Given this list of marker genes KDM5A, CDV3, SIPA1, CYBC1, HLA-C, TAP1, PSMB8, WIPF1, HLA-E, PHF11, HLA-A, MFNG, CD48, VAV1, IFI16, ELF4, CYTIP (cytohesin 1 interacting protein), RNF4, CD53, CORO1A, PSMB10 (proteasome 20S subunit beta 10), PSD4, PSME1, ARF6, GRK6 (NCBI Gene Id 2870), ACTR3, STAT6, RAC2, HCLS1, CSK, WAS, HLA-B, ARHGDIB, LAPTM5, CSNK1G2, TAPBP (NCBI Gene Id 6892), RAP1B, HLA-F, INPP5D, CBFB, STK10, SASH3, HLA-G, here is a description of the gene set: Human Gene Set: GNF2_INPP5D studied in species Homo sapiens Neighborhood of INPP5D Neighborhood of INPP5D inositol polyphosphate-5-phosphatase, 145kDa in the GNF2 expression compendium